Given this list of marker genes CYSLTR1, RGS1, CYSLTR2, LTB4R2, LTB4R, here is a description of the gene set: species: Homo sapiens A G protein-coupled receptor signaling pathway initiated by leukotriene binding to its receptor on the surface of a target cell, and ending with the regulation of a downstream cellular process. Human Gene Set: GOBP_LEUKOTRIENE_SIGNALING_PATHWAY